Given this list of marker genes Disc1, Cdc20, Dlgap4, Ywhaz, Rock1, Rock2, Sez6l, Sez6l2, Camk2b, Igsf21, Abl2, C1ql2, Sez6, Erbb4, Igsf9, Nfatc4, Vezt, Palm, Ccdc39, Chrdl1, Pfn1, Neurod2, Nrn1, Sybu, Neurl1a, Fgf7, Nrg2, Robo2, Hnrnpk, Dab2ip, Snx27, Nefl, Adgrb3, Bcan, Sema7a, Vps35, Arhgef15, Reln (NCBI Gene Id 19699), Fgf22, Nrxn1 (neurexin I), Cntnap1, Anapc2, Pten, Nlgn1, Cx3cr1, Adgrl1, Nfia, Ago2, Clstn1, Shank1, Dab1, Lnx1, here is a description of the gene set: The process that organizes a synapse so that it attains its fully functional state. Synaptic maturation plays a critical role in the establishment of effective synaptic connections in early development. Mouse Gene Set: GOBP_SYNAPSE_MATURATION studied in species Mus musculus